Given this list of marker genes CD79A, CD22, KLHL6, NFKBIZ, GRB2, IGHM, LYN, FCMR, NFAM1, LAT2, MS4A1, LIME1, CD79B, MIR34A, IGKC, SH2B2, BCAR1, NFATC2, CD72, FCRL3, CD81, PLCL2, MAPK1 (NCBI Gene Id 5594), BLK, BLNK, NFKB1, BANK1, MIR19A, FCGR2B (Fc gamma receptor IIb), IGHG4, PRKCB, IGHA2, SLC39A10, GCSAML, PTPRC, PLCG2, CD38, IGHE, CMTM3, PRKCH, IGHG3, IGHG1, PTPN6, PTPN22, IGLC6, IGLC1, BMX, IGHA1, LCK, NFKBIA (NCBI Gene Id 4792), STAP1, NCKAP1L, LPXN, IGLC7, ABL1, PIK3CD, MNDA, RFTN1, MEF2C, BTK, CTLA4, PLEKHA1, FOXP1 (forkhead box P1), BCL2, ITK, SYK, BAX, IGHG2, IGLC3, CD300A, CD19, GPS2, IGHD, GCSAM, MIR18A, SOS1, TEC, VAV3, here is a description of the gene set: The series of molecular signals initiated by the cross-linking of an antigen receptor on a B cell. Human Gene Set: GOBP_B_CELL_RECEPTOR_SIGNALING_PATHWAY species: Homo sapiens